Given this list of marker genes HYCC2, CNKSR3, IVD, EXOC3L2, KCNMB4, RAPGEF6, OLFM4, HECA, NSD3, IFT80, PRDM10-DT, SLC25A36, LMBR1, SMC4, SOCS5, INKA2, RNF130, TUT4, RELCH, DCHS1, ZDHHC23, HHEX, ZDHHC17, L3MBTL3, NXPE3, GPR18, CTDSP2, NLGN3, SMURF2, SNRK, RNF111, CYTH3, TLR1, USP38, SPATA6, RSRC2, NTS (NCBI Gene Id 96646, neurotensin), CCDC82, CDC14A (cell division cycle 14A), CTSS, KHK, MAJIN, GPR171, FAM13B, DENND1B, SHISA5, NPC2, FYCO1, BTBD1, CAB39, CYGB, KIAA0040, RNF2, TRIM34, SESN1, PIP4K2A, RASSF5, IZUMO1R, AHNAK2, GBP6, AAK1, ST8SIA6, BCL2L11, BPIFA1, NR3C1, FAM3C, LYPD6B, ITGA4, VSTM4, MGME1, CDK17, IP6K1, FRMD6, RNF170, KLHL24, FOXN3, KLHL26, ARHGEF4, TM6SF1, SSBP2, INSYN1, USP34, BANK1, KMT2C, ELK4, N4BP2L1, NCOA7, SAMTOR, TPO, ACADL, DGCR8, UBE2B, ZFAND6 (zinc finger AN1-type containing 6), ZNF292, FAM163A, PAXBP1, LAD1, CCDC28A, BACH2, CROT, SMAD1, CHST15, SLAMF6, FABP9, ZNF217, RESF1, LZTFL1, CD28, SLFN13, WDR17, FOXP1, YPEL2, VIT, DBP, SHPRH, INPP5F, RALGPS2, DTYMK, TTC3, CD3G, SMPDL3A, C4BPB, TNRC6A, KMT5B, PJA2, ABRAXAS2, ITGB2, IPCEF1, PLAAT5, ARHGAP39, D2HGDH, LEFTY2, SYNJ1, HECTD2, TEF, IRX2, PLEKHA1, NR2C2 (nuclear receptor subfamily 2 group C member 2), BMI1, GPR83, HP1BP3, FRMD8, AKR1C4, NT5DC1, ILF3, UTRN, MFSD6, ACVR1B, SLC12A6 (solute carrier family 12 member 6), CTSW, ZBTB4, SLC25A3, ITM2A, CLK1, GPR75, NHLRC1, SVIL, DOCK10, TUT7, ZKSCAN8, MBP, SESN3, ZC3H11A, ZMYM2, CIMIP2C, IL27RA, MTRFR, CNOT1, ZWINT (NCBI Gene Id 11130), LANCL1, TNRC6C, ZMAT4, PDK2, ATP10A, CTLA4, NCF2, DGKZ, TMIE, KAT2B, FAM91A1, ENDOU, ACADSB, ACCS, LCOR, MAPRE1, RCOR3, JADE2, IKZF4, CD96, DCP2 (NCBI Gene Id 167227), DYRK2, AP2A2, MAGEE1, LAMA2, VPS13D, MAP3K2, FAM76B, FILIP1, BBS2, CEP97, here is a description of the gene set: Genes up-regulated in T conv from lymph node of elderly (retired breeder) mice: wildtype versus PPARG knockout. We identified Pparg as a major orchestrator of the phenotype of adipose-tissue resident regulatory T cells (VAT Tregs). To establish the role of Pparg in shaping the VAT Tregs gene profile and cell dynamics, Tregs from lymph nodes and visceral adipose tissue of mice sufficient and deficient of Pparg expression in Tregs were double sorted for microarray analysis. Human Gene Set: GSE37532_WT_VS_PPARG_KO_LN_TCONV_UP species: Homo sapiens from publication Cipolletta D, Feuerer M, Li A, Kamei N, Lee J, Shoelson SE, Benoist C, Mathis D (PMID 22722857)